The following is a description of a gene set: The change in form (cell shape and size) that occurs during the differentiation of an endothelial cell. Mouse Gene Set: GOBP_ENDOTHELIAL_CELL_MORPHOGENESIS studied in species Mus musculus, and this is the list of marker genes: Amotl2, Cdh5, Tnmd (tenomodulin), Ift88, Pecam1, Plod3, Clic4, Notch4 (notch 4), Stc1, Met, Hoxa13, Heg1, Magi1, Cnmd, Col18a1, Arhgef26, Id1